The following is a description of a gene set: Transcription regulation during the cell cycle is crucial for ensuring genes are expressed at the right time and in the correct amounts, coordinating key processes like DNA replication, mitosis, and cell division. In our study, studied in species Homo sapiens Human Gene Set: PULVER_FOREY_CELLCYCLE_PEAKING_S1 Genes whose expression fluctuates during the cell cycle (pVal < 0.05) and peaks in early S (S1) in K562, and this is the list of marker genes: EZH2, ANTXR1, CCHCR1, KIFBP, SDC1, NTAQ1, NRM, CHAMP1, CENPQ, FOXO1, SMC6, SPART, PEAK1, HMGXB4, DHX35, XRCC6, ALDH5A1, H2BC18, DPY19L1, TSPAN3, UFD1, ZNF565, ZWINT, SCN8A, TCP11L1, ZBTB34, PPIG, DCUN1D4, RFWD3, PCLAF, BIN1, MCM7, DENND6A, NUP62, RAB11FIP2, CTDSPL2, UBIAD1, CDKN1A, CS, VOPP1, TFCP2L1, USP28, NHLRC2, STAM, EHD3, RNF167, AUNIP, DDIAS, NUP58, PXYLP1, ATP6V1A, ING3, MSH2, DDB2 (NCBI Gene Id 1643), RAD51AP1, VAV2, C2orf68, ATP1A1, C2orf42, FOXRED2, LCOR, ZNF398, EIF2S1, LEF1, FERRY3, TIMP3, SYK, CENPM, CEP290, DDX19A, GPR160, PSIP1, LPL, C2CD5, ANKH, DNMT1 (DNA methyltransferase 1), H2BC1, PKP2, IBA57-DT, E2F8, GYG2, TFDP1, CCDC93, NOS1AP, URB2, PARP2, ATP11C, TMEM209, AP1S2, NFX1, NETO2, HEMGN, ACVR2B, PIP4P2, SKP2, VPS29, CLK2 (CDC like kinase 2), SNX24, LNPK, MNS1, ADRA2C, DAND5, XRCC5, GYG1, ATAD2, NDOR1, ST3GAL4, SLC25A40 (NCBI Gene Id 55972), PPP1R15B, SLC35B2, XPNPEP1, SORBS3, CDK2, IDH2, ARHGAP24, FNIP2, DEPDC5, PLAGL2, FANCG, TLCD4, GLUD1, DEPDC7, KDM4C (lysine demethylase 4C), CHEK1, SLC16A6, YTHDF1 (NCBI Gene Id 54915), TFEB, NEDD4L, FOXD2, ZNF101, DYRK4, GZF1, ACO1, ORC1, PLPP2, LPGAT1, H2BC21, VAMP2, OSBPL11, SEMA3F, NUDT7, SEC23B, SUZ12, FECH, HPRT1, GPAT2, EIF4EBP2, TOPBP1, CASK, PCNX1, REV1, PKMYT1, SH2D1B (SH2 domain containing 1B), ZNF142, SETMAR, LPIN2, WDHD1, AKR1E2, RFC1, SIRT1, THY1, PLEKHG2, ATP2A1, AGK, H2AC6, NT5DC1, GNAZ, ALKBH1, CHSY1, TEDC2, BAZ1B (bromodomain adjacent to zinc finger domain 1B), NUP43, MTBP, ZFP1, PVR, LRP4, MND1, ZNF713, ATL3, GARRE1, NAA50, SLC25A21-AS1, PCDH9, CASZ1, BLM, GPD1L, DHFR, TTI1, ARSB, KBTBD4, CCP110, TLCD1, ZNF311, GGA2, FAT1 (FAT atypical cadherin 1), H2AC11, KAT7, KLF15, ACKR1, DSCC1, SLC2A6, RFC5, SHTN1, TMX4, H1-3, IMMP2L, H2BC5, CDK2AP1, WBP4, SNX5, H2BC13, GINS3, UBE3D, VEZF1, FIGNL1, PDK3, ITM2C, ISOC1, FCGR3A, CDS2, BARD1, DNAH3, CDC7 (cell division cycle 7), RRM1, SCCPDH, MAP3K5, ZC3H10, ACAA2, GMNN, SMC5, SPECC1, PLAG1, CC2D2A, DEK, USP49, TRIO, DUSP15 (dual specificity phosphatase 15), SLC39A8 (solute carrier family 39 member 8), MORC4, H2AC1, SRSF10, HAUS1, DSN1, JADE3, DGKH, MAJIN, RCAN1 (NCBI Gene Id 1827), NXPH3, MEX3D, RPRD1B, ZNF236, YEATS4, FAM161A, ACHE, LRRC40, TBC1D1, GSTCD, POC1B, NUP160, C19orf47, ERLIN1, GINS1, EIF4E3, RBM17, APLP1, DDX11, NUDT21, SUCLG2, RBBP7, SIMC1, SH3PXD2B, BCL7B, CDC45, LRRC45, NSMCE4A, NSD3, N4BP2, LRRC57, KCTD3, SLC12A2, PARD3, HECTD2, WWOX (WW domain containing oxidoreductase), ACYP1, RAE1, SART3 (spliceosome associated factor 3, U4/U6 recycling protein), MOCS2 (NCBI Gene Id 4338), SYCE2, KANSL2, RTTN, MAPK1IP1L, EOGT, SLC11A2, OAS3, TSPAN9, ZEB2, WDR41 (WD repeat domain 41), CDT1, TMEM54, ZNF730, PAK1, SMARCC2, MRE11, PYGO2, DDX46, VRK1, NUP214 (nucleoporin 214), NCOA2, RABIF, WDR7, TCFL5, CA1, FGF13, PI4K2B, TM7SF3, DNA2, LRRC61, SYNE2 (spectrin repeat containing nuclear envelope protein 2), RAD18, RFLNB, EXO1, KAT14, NUP85, EMP2, SLC25A28, TONSL (tonsoku like, DNA repair protein), HAUS3, ZBTB21, SUPT6H, BRCA2 (BRCA2 DNA repair associated), HES4, H3C12 (NCBI Gene Id 8356), SHMT1 (NCBI Gene Id 9316), DMC1, MASTL, LCMT2, TMEM107, KMT2A, SH3GL3, RNF144A, FEN1, CPVL, PKNOX1, CPSF7, IRAK1BP1, FANCM, MPP2, UBE3C (NCBI Gene Id 9690), EXOG, TASP1, RPA3, MTHFD1, NASP, RIMS3, RADIL, OR6A2, DYNC1LI2, DDX55, TP53I11, SHISA8, LMF2, ZGRF1, POLE, ONECUT2, PHF10, ZDHHC4, PPIF, SPPL2A, ZNF250, CDC23, TRIM37, IFT25, METTL17, NCAPD3, PGR, CENPH, CABLES2, PBLD, ACSBG1, RFC3, HNRNPAB, IPO7, TAF3, RBM10 (NCBI Gene Id 8241), ZNF384, AKAP11, SLC2A4RG, ATAD5, SMC2, CISH, FAM111A, HEG1, RAD51C, ADCY1, PPP4R3A (NCBI Gene Id 84644), C3orf52, IPO9, SBDS, CNOT10, PGRMC1, E2F7, NUP155, TOE1, BRD3, CCDC15, XK, CMKLR1, SLC16A9, ALMS1, CNTN5, RAD54L, FANCB, CYB5R2, JAM3, CTHRC1, SLC10A7, ITGB3BP, PPIH (peptidylprolyl isomerase H), PDE1C, RAD9B, SMCO4, RPN2, USP31 (NCBI Gene Id 57478), TMEM241, RFC2, FOXN3, QDPR, SLC25A42, EIF5, CPNE8, BCLAF1 (NCBI Gene Id 9774), MOCS1, WWC2, BRCA1, PLCG1, CEP78, SRD5A1, BRPF1, EML5, DERA, SFMBT1, SNRNP27, PRIMPOL, IL6, SREK1, SULT4A1, STX17, MIR9-1HG, FARP1, RALGAPA2, TMOD2, SCG3, LCA5, ATG4D, ORC6, AQP11, SSX1, CYB5RL, ZNF438, EDRF1, CEP57, USP18, GULP1, H4C3, IGF2R, MLH1, CDYL2, KIFAP3, SECISBP2, UBA2, PTAR1, GLIPR2 (GLI pathogenesis related 2), TAF4B, DUT, KNTC1, DLST, MATCAP2 (NCBI Gene Id 23366), SP2, KIF21A (NCBI Gene Id 80819), GGH (NCBI Gene Id 8836), ESCO2, ZNF441, CDK14, CDC5L, PTPRF, RCBTB1, AOPEP, POLA2, SSX3, MCUB, NR2C2 (NCBI Gene Id 7182), ZWILCH, PPP1R3E, ENOPH1, DNAJC9, TPD52, CENPK, H2BC11, SIRPA, ARHGEF16, HERC3, FIRRM, ADAMTS3, H2AC13, POLA1, TP63, TBXA2R, SMC3, AK3, RAB3IP, POGLUT2, WWP1, RAB27A, NUP62CL, NAA16, TULP3, TPGS2, H2BC26, H1-4, CLGN, PDCL, TUBGCP3, XNDC1N, MAP3K21, CENPU, H3-4, FANCA, FAM76B, RAD1, VCF1, DIPK2A, SFXN1, RECQL4, TMEM106C, PBX3, PRIM2 (DNA primase subunit 2), DPF3, CASP2, KAT2B, PRADC1, LMO4, THUMPD1, BRME1, LIN54, PRR3 (NCBI Gene Id 80742), C4orf46, ELOVL7, NEDD4, TCF19, USP1, TRA2B, FIBCD1, KATNAL1, HSPA12A, H4C8, NECTIN1 (NCBI Gene Id 84853), GDF15, FAM219A (family with sequence similarity 219 member A), CNN2, MAN2A1, CHD8, PHIP, TMEM143, GRPEL2, STMN1, MTMR1, UGGT1, SP3, TUSC3 (tumor suppressor candidate 3), PLEKHG3, SRSF6, DEUP1, ATP6V0B, IPO5, KIF16B, RFX2, UGT8, CENPP, RBL1, POGLUT3, POU4F1, RBFA, MCM8, SLC30A4, ZNF16, ANKRD36C, BBIP1, STS, DERL3, MPP7, EME1, PRKAG2, HMGN1, CFAP119, PRPS2, ZBTB2, ORC3, INPP5B, CERS6, SLC2A13, H3C13, NCBP3, MAPK8, SCN5A, FRMD6, PPM1L, PARP4, NAP1L4, GINS4, CENPS, SLC13A4, ABCD3, TXLNG, TYMS, TXNDC16, KBTBD13, GK, ALG9, POLE2, RBBP4, MED14, RPA1, MAPK9, GADD45A, BRIP1, S100PBP, PPP1R12B, PRKDC, RIF1, PABIR3, SAAL1, RAD51, NEDD1, PGM2, MAPDA, KCNS3, GUSB, THAP7, MICB, PM20D2, ZNF672, RASGEF1B, RNPS1, HEPACAM2, CTDSPL, STPG1, UBE2D2, SIAH1, RASSF8, ZNF678, C18orf54, RAVER2 (NCBI Gene Id 89143), ZNF695, HACD2, PUDP, PRKD3, ACP2, DNAJC21, KIAA1549, PREX1, PAXIP1, LSM11, PGAM1, ZDHHC20, IGF1R, IMPA2, SYNE3, TMTC4, AIF1L, GAL, PPM1D, CFAP20, SCAPER, ARL13B, STAG2, B3GLCT, CCDC50, SLC37A2, SUPT16H, SP1, LANCL1, TMEM117, TAF5L, GPN3, ZW10, FTO, SPIN1, LYST, COL14A1, HEXB, REV3L, MAN1A2, COPS3, CTNNAL1, PIDD1, PRKX, NCALD, ITPR3, ZDHHC2, ADNP2, SUPV3L1, PRIM1, AQP3, CEP152, CCDC14, IL12RB1, KCNJ11, MALT1, CLN8, ARHGAP44 (NCBI Gene Id 9912), NEK1, RPA2, ERMAP, CSRP2, BUD13, EIF2B1, RRM2, CDCA7L, MGAT4A, MDM2, CTPS1, SLC44A1, COCH, YWHAQ, DCAF1, BAIAP2L1 (BAR/IMD domain containing adaptor protein 2 like 1), PAICS, HEYL, SOCS3